Given this list of marker genes CX3CR1, CLIP1, APPL2 (NCBI Gene Id 55198), CARMIL2, CARMIL1, APPL1 (adaptor protein, phosphotyrosine interacting with PH domain and leucine zipper 1), ANKFY1 (NCBI Gene Id 57500), NCL, MMP14, here is a description of the gene set: species: Homo sapiens Human Gene Set: GOCC_PINOSOME A membrane-bounded, uncoated intracellular vesicle formed by the process of pinocytosis.